The following is a description of a gene set: Genes up-regulated in SCLC (small cell lung cancer) cells with acquired resistance to ABT-737, an inhibitor of the BCL2 family proteins. from publication Hann CL, Daniel VC, Sugar EA, Dobromilskaya I, Murphy SC, Cope L, Lin X, Hierman JS, Wilburn DL, Watkins DN, Rudin CM (PMID 18381439) Human Gene Set: HANN_RESISTANCE_TO_BCL2_INHIBITOR_UP Bcl-2 is a central regulator of cell survival that is overexpressed in the majority of small cell lung cancers (SCLC) and contributes to both malignant transformation and therapeutic resistance. We compared primary SCLC xenografts prepared from de novo human tumors with standard cell line-based xenografts in the evaluation of a novel and highly potent small molecule inhibitor of Bcl-2, ABT-737. ABT-737 induced dramatic regressions in tumors derived from some SCLC cell lines. In contrast, only one of three primary xenograft SCLC tumors showed significant growth inhibition with ABT-737. Explanations for this apparent dichotomy may include relatively low expression of Bcl-2 in the primary xenografts or inherent differences in the model systems. The addition of etoposide to ABT-737 in the primary xenografts resulted in significant decreases in tumor growth, underscoring the clinical potential of ABT-737 in combination therapy. To identify factors that may contribute to resistance to ABT-737 and related inhibitors, we isolated resistant derivatives of an initially sensitive cell line-based xenograft. Acquired resistance in this model was associated with decreases in the expression of the primary target Bcl-2, of proapoptotic partners of Bcl-2 (Bax and Bim), and of Bcl-2:Bim heterodimers. Expression profiling reveals 85 candidate genes demonstrating consistent changes in gene expression with acquired resistance. Taken together, these data have specific implications for the clinical development of Bcl-2 inhibitors for SCLC and broader implications for the testing of novel anticancer strategies in relevant preclinical models. species: Homo sapiens, and this is the list of marker genes: KCNK16 (NCBI Gene Id 83795), ELAVL3, ZNF91, OLFM1, ATP8B2, KCNT1, SST, DCX, MXRA5, HOXB9, MT1G, FSCN1, NSG1, NPTX2, BRSK2, ITM2C, PCSK1N, VCX, STMN2, GPX2, CD81, GNG2, TNFRSF8, HBA1, SPRR2F (small proline rich protein 2F), PPP2R2C, FLNC, TAGLN2, MT1F, RTN1, IGSF9, MCUB, SCD, EEF1A2, FAM171A1, PNMA2